The following is a description of a gene set: Mouse Gene Set: GOBP_MYELOID_LEUKOCYTE_DIFFERENTIATION studied in species Mus musculus The process in which a relatively unspecialized myeloid precursor cell acquires the specialized features of any cell of the myeloid leukocyte lineage., and this is the list of marker genes: Ccr1, Ifi214, Vegfa, Ripk1, Cd74, Pla2g3, Hoxa7, Siglec15, Gpr68, Ccl19 (C-C motif chemokine ligand 19), Nkx2-3, Farp2, Stat5a (NCBI Gene Id 20850), Il1rl1, Atp6ap1, Tjp2, Pira12, Creb1, Cebpe, Ifi203, Il17c, Ifi213, Iapp, Nfix, Nrros (NCBI Gene Id 224109), Ighe, Myc, Ostm1, Tcta, Pafah1b1, Car2, Hax1, Tmem64, Prdm16, Il15, Tyrobp, Ror2, Hcls1, Runx1, Il34, Gata1, Tnf, Myh9, Jagn1, Ndp, Clec2i, Fes, Il4, Ikzf1, Ppargc1b, Rb1, Cul4a, Cebpa, Dlk1, Snx10, Nfatc1, Junb, Fos, Pira1, Irf4, Fadd, Lef1, Zbtb7a, Ppp3ca, Fam3c, Ltbr, Gata2, L3mbtl3, Efna2, Clpb, Bbln, Adam8, Kdm1a, Pik3r1, Gpr137, Socs1, Spi1, Gfi1b, Trf, Myd88, Cflar, Fshb, Lif, Acin1, Kitl, Enpp1, Zbtb46, Il25, Ptpn2, Pir, Il20, Nedd9, Cd4 (CD4 antigen), Trem2, Il23a, Cldn18, Tcirg1, Fbn1 (fibrillin 1), Rbpj, Csf1r, Gimap3, Ifi206, Erfe, Tnfrsf11a, Dcstamp, Mef2c, Calcr, Itgam, Il33, Foxp1, Lrrc17, Camk4, Oscar, Il12b, Fam20c, Tnfrsf11b, Adipoq, Eif2ak1, Fbxw7, Nr3c1, Diaph3, Evi2, Gsk3b, Tlr4, Fosl2, Lilrb4a, Ifng, Gata3, Tnfsf9, Ccl3, Traf6, Fstl3, Srp54c, Ccr1l1, Bmp2, Tnfsf11, Lrrk1, Ubd, Cited2, Notch2, Cd101, Prkca, Vps54, Ap3b1, Cbfa2t3, Itgb3, Ifi207, Itgb8 (integrin beta 8), Prtn3, App, Mafb, Qki, Tob2, Ccl5, Id2, Rptor, Large1, Ccdc39, Esrra, Ifi209, Relb, Lbr, C1qc, Sirt1, Naglu, Nme2, Trib1, Lyn, Anxa2, Mir223, Il5, Pou4f1, Ceacam1, Sp3, Tesc, Bap1, Lilrb4b, Srp54a, Psen1, Eeig1, Nme1, Ccr7, Tescl, Apcs, Gpr55, Tgfb1, Tfrc, Gnas, Cdk6, Inpp5d, Rbp1, Glo1, Slc4a2, Arid3c, Inpp4b, Cd81, Clec2g, Ctnnb1, Cd300lf, Sh3pxd2a, Apc, Mndal (NCBI Gene Id 192690), Pilrb1, Prxl2a (peroxiredoxin like 2A), Pias3, Rara, Ccn4 (cellular communication network factor 4), Kit, Il3, Bmyc, Ndfip1, Clec2d, Gba1 (glucosylceramidase beta 1), Gab3, Gpr137b, Igsf23, Asxl2, Il17a, Fasn, Casp8 (NCBI Gene Id 12370), Batf3, Hhex, Dhrs7b, Batf, Tlr2, Gmpr2, Plcb1, Gimap5, Ubash3b, Psen2, Cartpt, Batf2, Cebpb, Pde1b, Gab2, Nkap, Srp54b, Ift80, Sbno2, Ifi203-ps, Pou4f2, Gpr183, Ireb2, Epha2, F2rl1, Bmp4, Sfrp1, Jun, Tgfbr2, Evi2b, Tnfaip6, Klf10, Ccl9 (NCBI Gene Id 20308), Tmem178, Spib (Spi-B transcription factor (Spi-1/PU.1 related)), Mitf, Epsti1 (NCBI Gene Id 75988), Gpc3, Zfp36l1, Src, Med1, Tfe3, Csf1, Ucp2, Fgfr3, Fcer1g, Pparg (NCBI Gene Id 19016), Thoc5, Hsf1, Mtor, Mfsd8, Pirb, Cd109, Il31ra, Csf3, Ifi208, Tal1, Ctnnbip1, Csf2, Ocstamp, Slc9b2 (NCBI Gene Id 97086), Vps13a, Mapk14, Ninj1, Nf1, Ifnb1, Ltf, Tspan2, Chuk, Fshr, Itgb6, Rassf2 (Ras association (RalGDS/AF-6) domain family member 2), Zfpm1